Given this list of marker genes RILPL2, CDK6, RAB1B (RAB1B, member RAS oncogene family), BMP4, TFAP2C, ARHGEF26 (NCBI Gene Id 26084), F11R, BFSP2, IL6ST, CLOCK, CLIC4, NKX2-2, SRC, PGR, AKT1, ROCK2, NPHS1, TIGAR, IHH, AKR1B1, SMO (smoothened, frizzled class receptor), PPP1R16B, EPB41L5, FOXJ1, FOXA1, PPP1R12A, KCNE1, F2RL1 (NCBI Gene Id 7901), AMOTL2, NPHS2, PECAM1 (NCBI Gene Id 5175), TJP2, MAGI2, B4GALT1, PDGFB, TNMD, HPSE, FASN, ZDHHC21, ADAMTSL4, RAP2C, CLDN5, GATA2, NOTCH1, CDSN, VEGFA, SLC4A5, VIM, KDF1, ASXL1, PKHD1, BHLHA15, NKX6-1, HOXB13, TP63, FLNB, RDX (NCBI Gene Id 5962), S1PR2, GPR4, FOXC2, TJP3, ONECUT2, ARID4B, E2F4, CCDC88C, CDH5, SIPA1L3, TNFRSF1A, HOXA13, NKX3-2, MYD88, YIPF6, AMPD2, KDR, ABCA12, CEBPA, IFT74, DACT2, RAPGEF3, PROC, TFCP2L1, EPAS1, BMAL1, DNASE1L2, SOX18, GSK3B, MIR29B1, ST14, HYDIN, GSK3A (glycogen synthase kinase 3 alpha), RAPGEF2, WNT7B, PALLD, MYADM, PROX1, MYO1E, VCL, ESR1, FRMD6, TGFB1, FOXP3, IL1B, FRZB, BAD (BCL2 associated agonist of cell death), POF1B, NOTCH4, FZD5 (frizzled class receptor 5), INSM1, FER, SLC9A4, KLF5, ROS1, VSIG1, PLCB1, SIX3, CRYAA, RARG, WNT7A, LUZP1, TMIGD1, RAC1, GPX1, HSD17B4, ABI2, CLDN3, RAP1A, RARA, ICAM1, PDE2A, TJP1, CDH2, RAB13 (NCBI Gene Id 89672), SOX9 (NCBI Gene Id 6662), LAMB2, ABCB1, PLEC, NR5A2, RAPGEF1, NTRK1, BMP6, STC1, FRS2, GRHL2, CRYGB, FEM1B, EDNRA, EPHA2, ADAM7, COL18A1, IQGAP1, ATF4, SPINT2, RAP2B, YAP1, TMEM79, WNT5A, MARVELD2, CCM2, MAGI1, SIDT2, HOXA5, BCL11B, DLL1, DMRT1, PDE4D, RAP1B, RAPGEF6, TNF, EDNRB, RARB, IKBKB, NOTCH2, TBC1D20, HAPLN2, C1GALT1, FSHR, MIR541, PLOD3, GATA1, ADIPOQ, KRT2, TMOD1, GPAT4, AR, FOSL2, FLNA, ROBO4 (NCBI Gene Id 54538), GDF11, ID1, ADD1, SCX, MET, RILPL1, TLR9, BFSP1, RHEB, FAT1, RFX3 (regulatory factor X3), WNT5B, PTPRS, ONECUT1, RAB1A, ROCK1, ATRX, MSN, JAG1, S1PR3, EXPH5, SFN, ARID4A, PODXL, EZR, PRDM1, VEZF1, RAB25, ACTA2, SPDEF, GSTM3, AFDN, NUP210L, FNDC3A, HEG1, PAX6, XBP1, HIF1A, BMP5, PDPK1, CLDN1, SOX8, here is a description of the gene set: The process whose specific outcome is the progression of an epithelial cell over time, from its formation to the mature structure. An epithelial cell is a cell usually found in a two-dimensional sheet with a free surface. Human Gene Set: GOBP_EPITHELIAL_CELL_DEVELOPMENT studied in species Homo sapiens